Given this list of marker genes 4921504E06Rik, Nos1, Spesp1, Sox3, Lgi3, Basp1, Edn3, Spag6, Zfp516, L1td1 (NCBI Gene Id 638744), 1700067K01Rik, Cntnap2, Riiad1, Ces5a, Tnfsf13b, Rph3a, Fstl5, Adam1b, Dpp6, Hsf5, Adam32, Gabrq, Fgf6, Rab9b, Taf7l, Nscme3l, Jak3, Slc2a5, Plaat1, Tnfaip8l2, Rbm28, Cryga (NCBI Gene Id 12964), Pcdha4, Papolb, Bahcc1, Tex13b, Bex4, Epha1, Brdt, Hspb3, Tmc8, Il1rapl2, Ccdc83, Igsf1, Slc15a3, Lkaaear1, Kcne5, Tex19.1, Slc25a31, Dnajb8, Bex2, Tm6sf2, 1700102P08Rik, Drosha, Dlgap1, Trpm6, Zfta, Gnmt, Zdhhc25, Chrdl1, Far2 (NCBI Gene Id 330450), Spag16, 1700020N01Rik, Rec8, Prss44, Pdha2, Pcdha1, Chrm4, Tdrd1, Crybb3, Plcxd1, Pcdhb20, Pcdha2, Gigyf1, Pcdha5, Dmrtc1a, Npas4, Asz1, Sycp2, Trpc3, Ccdc110, Hmgcll1 (NCBI Gene Id 208982), Mycs, 1700018B24Rik, Ptpn6, Nxph2, Henmt1, Pcdha8, Kcnv2, Map7d2, Necab1, Pcdhb21, Camkk2, Krt2, Chad, Tex12, Nsd1, Gtf2a1l, Pcdha12, Tbx22, Mgat4d, Nrsn1, Plvap, Scg5, Clvs2, Stra8, Tex11, Magix, D1Pas1, Glra1 (NCBI Gene Id 320836), Dpep3, Nlgn2, Krt4, Syp, Bcl2l10, Them7, Pramel1, Chst5, Bhlha15 (basic helix-loop-helix family, member a15), Pcdhb10, Spire1, Myh14, Trpm1, Pcdha10, Gpr182, Npb, Rbfox1, Ldhal6b, Zfp385a, Arhgap4, Piwil1, Ccin, Rnf225 (NCBI Gene Id 97353), Tex101, Sstr2, Sycp3, Gsn, Cdx4, Cnih2, Gpr101, Krt27, Sap25, Camk2a, Lypd2, Spag8, Krt26, Gpr158, Il12rb2, Synpr, Arx, Actl7b, Fxyd2, Rbp3, Sox15, Deup1, Pcdhb1, Olfm3, Pabpc6, Slc35f4, Wbp2nl, Slc2a9, Vwa1, Pcdhb15, Pcsk1n, Nherf4, Adamtsl1, Dhdh, Mael, Clvs1, Rhbdl1, Pcdha3, Pou3f4, Abhd16b, Sec1, Acrbp, Prss45, Krt85, Gdap1, Fam178b, Ptgir, 4930524B15Rik, Dmc1, Fgf22, Rcvrn, Sohlh2, Marveld2, Pcdha9, Rnf138rt1, Tektip1, Ldoc1, Pcdha6 (protocadherin alpha 6), Slitrk4, Tssk2, Spmap1, Hormad2 (NCBI Gene Id 75828), Adam1a, Msh4, Gfap, Mtnr1a, Il20rb, Lag3, Pcdha11, Ltb4r1, Nr0b1, Col9a3, Krt18, Htr5a, Vsir, Ildr1, Asphd2, Thsd7b, Cacng2, Klk10, Ddx4, B3gnt8, Pcdhb4, Speg, Rnf17, Sh3d19, Irs4, Cnga4, Naa11, Scg3, Slc26a8, Fscn2, Plce1, Kcnj11, Htr2c, Gpr50, Dnd1, Dusp13b, Ezhip (EZH inhibitory protein), Pcdhac1, Eppk1, Hoxa3, Tle6, Sycp1, Pcdha7, Rho, Tktl2, Ly6k, Ccdc185, Omp, Pcdhb18, Apoc1, here is a description of the gene set: Genes with high-CpG-density promoters (HCP) with unmethylated histone H3 in MEF cells (embryonic fibroblast). studied in species Mus musculus Mouse Gene Set: MIKKELSEN_MEF_HCP_WITH_H3_UNMETHYLATED We report the application of single-molecule-based sequencing technology for high-throughput profiling of histone modifications in mammalian cells. By obtaining over four billion bases of sequence from chromatin immunoprecipitated DNA, we generated genome-wide chromatin-state maps of mouse embryonic stem cells, neural progenitor cells and embryonic fibroblasts. We find that lysine 4 and lysine 27 trimethylation effectively discriminates genes that are expressed, poised for expression, or stably repressed, and therefore reflect cell state and lineage potential. Lysine 36 trimethylation marks primary coding and non-coding transcripts, facilitating gene annotation. Trimethylation of lysine 9 and lysine 20 is detected at satellite, telomeric and active long-terminal repeats, and can spread into proximal unique sequences. Lysine 4 and lysine 9 trimethylation marks imprinting control regions. Finally, we show that chromatin state can be read in an allele-specific manner by using single nucleotide polymorphisms. This study provides a framework for the application of comprehensive chromatin profiling towards characterization of diverse mammalian cell populations. from publication Mikkelsen TS, Ku M, Jaffe DB, Issac B, Lieberman E, Giannoukos G, Alvarez P, Brockman W, Kim TK, Koche RP, Lee W, Mendenhall E, O'Donovan A, Presser A, Russ C, Xie X, Meissner A, Wernig M, Jaenisch R, Nusbaum C, Lander ES, Bernstein BE (PMID 17603471)